The following is a description of a gene set: from publication Chen Y, Wang X (PMID 31504780) studied in species Homo sapiens Human Gene Set: MIR1304_5P Genes predicted to be targets of miRBase v22 microRNA hsa-miR-1304-5p in miRDB v6.0 with MirTarget v4 prediction scores > 80 (high confidence targets)., and this is the list of marker genes: MINDY2, CXADR, VPS37A, PACRGL, CHST3, ENOX2, PRR9, STRIP2, DIPK1A, MEIS2, TIAL1, C9orf40, HMGA2, ALS2CL, CNOT4, FBXL17, LRRC7, PABIR2, WFIKKN2, GJB2, AKR1B1, ZFP28, LARP4B, BHLHE41, FBXO45, ZNF704, DNER, DCTD, SYNPO, CALM2, GPATCH2, ZNF319, KCNK4, TSPEAR, ITGA1 (NCBI Gene Id 3672), PRKG1 (NCBI Gene Id 5592), USP47 (ubiquitin specific peptidase 47), PPP2R3A, CHP1, CAPRIN2, ZNF100, PLA2G3, IPO11, SCYL2, LY6E, C9orf85, GNAQ, SLC35F6, PPIL6, MYC, CENPL, CCDC198, PCGF3, FUT4, ENTPD1, PFKFB2, B4GALT6, MKX, STX6, TIMM9, RTL9, WNT3A, BAIAP2, RAD1 (RAD1 checkpoint DNA exonuclease), ZNF134, ACBD3, CPEB4, BCAT1, MRPL30, DPYSL3, CXCL13, TCP10L2, KAT2B, CDH13, NR2E1, ICE2, ARPP19, OCSTAMP, PRUNE2, SPICE1, MAP9, NMUR2, GRK5, SENP5, SOX5, SPIRE1, CYTH1, MEF2C, CCN2, RNF168, UNC5D, GNPAT, TLE4, SCYL3, PLXNA4, CSTF3, SLCO5A1, CCNG1, ANTXR2, UQCRQ, EXOG, HEY1, ACVR1C, PDE4A, CMTM4, VPS13D, EFEMP2, ZSWIM6, ARMCX5, VSTM4, ELAPOR1 (NCBI Gene Id 57535), ADIPOR2, PTPN11 (protein tyrosine phosphatase non-receptor type 11), ANK2, ZBTB25, LYPD3, PTPRJ, GORAB, SLC4A4 (solute carrier family 4 member 4), TMBIM6, TET3, UHRF1 (NCBI Gene Id 96185), ZDHHC6, POGLUT3, MPZ, FOXL2NB, NPHP3, TAGAP, STAT5B, SSH2, AKR1C2